The following is a description of a gene set: studied in species Homo sapiens The chemical reactions and pathways involving dTMP, deoxyribosylthymine monophosphate (2'-deoxyribosylthymine 5'-phosphate). Human Gene Set: GOBP_DTMP_METABOLIC_PROCESS, and this is the list of marker genes: DUT, DCTD, TYMS, SHMT1, NT5C, TYMP, UPP1